Given this list of marker genes Avp, Avpr1a, Pibf1, Ptgs2, Anxa1, Cd74, Sirt1, Pla2g3, Abcd2, Il1b, Abcd1, Pla2g4a, Mapk9, Fabp5, here is a description of the gene set: Mouse Gene Set: GOBP_REGULATION_OF_UNSATURATED_FATTY_ACID_BIOSYNTHETIC_PROCESS Any process that modulates the frequency, rate or extent of unsaturated fatty acid biosynthetic process. studied in species Mus musculus